The following is a description of a gene set: Human Gene Set: GOMF_HISTONE_H4_DEMETHYLASE_ACTIVITY studied in species Homo sapiens Catalysis of the removal of a methyl group from a modified lysine residue of the histone H4 protein. This is a dioxygenase reaction that is dependent on Fe(II) and 2-oxoglutarate., and this is the list of marker genes: KDM7A, JMJD6 (jumonji domain containing 6, arginine demethylase and lysine hydroxylase), PHF8, PHF2, RSBN1